Given this list of marker genes CRELD1, ST14, RPL35A, NOTCH3, HCCS, PMM2, POMGNT2, ANK1, SHROOM4, ROBO3, POLR1C, CRX, PDPN, PPP1R13L, ABCB6, RAF1, ATPAF2, ACTG1, MAPK1, CEP120, FH, IL12A, BBS12, MAPRE2, RRAS2, COX7B, COQ2, SRCAP, NHS, BBIP1, ERCC1, ABCA1, CRYBA4, DNA2, ZNF513, LAMB1, ATP7B, CHMP1A, RNU4ATAC (NCBI Gene Id 57788), MAK, CHD7, MAN2B1 (mannosidase alpha class 2B member 1), RPL18, TFAP2A, RNF113A, VSX1, RLIM, UROS, TUB, GNPAT, PDZD8, MIR204, LAMB3, IDH1, IQSEC2, SIN3A, MT-ND5, ATAD3A, RNF2, DSG4, ADAMTSL4, PLXND1, KRT74, TRIM37, DDB2 (NCBI Gene Id 1643), LUZP1, HERC2, APOA2, RPS10, CHSY1, PIGQ, SMAD4, RPE65, LRP5, MT-TV, ITPA, IMPG1, SMC5, PRG4, COL5A1, SF3B2, KMT2B, FREM1, FIG4, PRR12, COMT, B9D2, EIF2B2, GATA1, WDR35, SAMHD1, BLOC1S3, BBS7, B4GALNT1, KRT25, SLC4A4, DEAF1, PEX2, PEX19, MOCS1, SLC25A24, LPAR6, BTNL2, TMEM70, NIPBL, PPP2CA, DGCR2, FANCB, FLNB, IL10, SUFU, GATAD2B, ITPR1, DISP1, HLA-B, MTSS2, PCYT1A, ARCN1, FAS, NDN, BBS9, SLC40A1, SNRPN, HS2ST1, PPP1R17, CREBBP, PSAT1, PDE6G, FKRP, SLC39A8, B3GALNT2, FGD1, KCNV2 (potassium voltage-gated channel modifier subfamily V member 2), KRT83, NPHP4, ZBTB7A, POMT1, XRCC4, CEP41, RRAS, RPL15, PTPN11, SETBP1, COL2A1, ZFHX2, GALE, STIM1, NOG, GLA, OPN1LW, LAMC2, AASS, MAX, SLF2, SOX10 (SRY-box transcription factor 10), TRPV3, USB1, PRDM12, DBR1, DUX4, USH2A, SUOX, MYO7A, RPS17, PTCH1, NF2, MBTPS2, RP1, SLC2A1, FBN2, GALNT2, ATP5F1E, NDP, PACS2, PERCC1, ETFA, NAA60, SPEN, TBC1D2B, LYZ, SMC3, CRYGB, NF1, DDX6, SPRTN, MAPKAPK5, REEP6, CC2D2A, CLPB, ALDH18A1, IL2RB, RBP4, MINPP1, HSPA9, AGBL5 (AGBL carboxypeptidase 5), CBY1, ASH1L (NCBI Gene Id 55870), RFWD3, KIF11, ERCC5, TAP1, TBCE, STS, RP1L1, CBL, WAC, PDGFRB, IFNGR1, PIGG, PEX7, SULT2B1, TAF6, DDR2, ARSG (NCBI Gene Id 22901), TYRP1, CRYGD, RBP3, PANK4, TYR, PAH (phenylalanine hydroxylase), FDXR, SH3PXD2B, PEX13 (NCBI Gene Id 5194), VLDLR, POLA1 (DNA polymerase alpha 1, catalytic subunit), MAT2A, ARID1B, JAG1, IKZF1, HMX1, SOS2, PRKAR1B, PRPF8, AKT1, TCF4, TCOF1, MAP3K7, NR2E3, PHOX2B, ERCC4, KITLG, CCR1, PRPF4, TINF2, HLCS, FGF3, SLC33A1, TMEM67, FGF5, PDE6B, SEC24C, RNF13, USP45, MED13L, CAMK2B, GLRB, SHH, SETD5, GABRD, MT-ND1, H1-4, B9D1, TBC1D24, MT-TK, SETD2, NEUROD2, CLDN19, GAS1, GP1BB, ABCG8, BAP1, INVS, FLVCR1, TOGARAM1, NDUFB11 (NADH:ubiquinone oxidoreductase subunit B11), XPA, KDSR, PBX1, SMPX, CHD6, ROM1, GDF3, GJB4, DYM, TXNDC15, WRAP53, SLC2A10, TMTC3, DNAJC30, TENM3, SLC29A3, FKBP6, SLC39A4, KIAA0586, SDR9C7, BRCA2, DHCR7 (7-dehydrocholesterol reductase), LMNA, RPL9 (ribosomal protein L9), SLX4, HYCC1, CLDN11, ADAMTS17, TBR1, JAM3, CHST3, HDAC4, CCDC28B, MYT1L, ELN, FGFR3, ANTXR1, TONSL, RPS15A, PLCG2, CTDP1, ABCA4, CRYAA, RAB3GAP2, ADA2, CYSLTR2, DNMT3B, FOXH1, TUBGCP6, SDHC, TBC1D20, GTF2I, UBIAD1, VIM, CA8, ZFX, GNPTAB, TBX22, ASPH, NRL, RECQL4, EPHA2, MT-CO1, LRMDA, DYNC2H1, COL1A1, RAI1, CDHR1, TUBA3D, GTF2E2, SPRED2, MFAP5, NOTCH2, COL9A1, SDHB, COL4A4, GLI3, SHOC2, PTEN, MIPEP, NPHP1, COL8A2, RAP1B, USH1G (USH1 protein network component sans), RAD51C, HPS1, RB1, IL2RA, MYOC (myocilin), GLIS3, CRYBA2, FKTN, KIZ, RPS29, NOD2, GJA1, FRG1, ADNP, LAMB2, ERCC2, TGM1, TERT, ELP1, HK1 (hexokinase 1), HNRNPA2B1, HNRNPDL, COL9A3, TEAD1, RNF125, TMEM237, BBS4, IKBKG, LAMA3, H19, TBC1D7, CACNA1F, RPGR, PRPF3, MOCS2, VCP, EXOSC2, EDNRB, PRPH2, FLI1, CEP78, COL3A1 (collagen type III alpha 1 chain), PLCB4, KMT2C, LRP2, RRM2B, OCLN, MT-CO3, MKKS, MPV17, PLEC (NCBI Gene Id 5339), SEC23B, ZEB1, ALG2, TREX1, PDE6D, DHX38, ELMO2 (NCBI Gene Id 63916), MMP14, KDM5A, CNBP, NPHP3 (nephrocystin 3), ATP6V1B2, POMK, BCAP31, FOXL2, ARSL, TGFB3, DTNBP1, UBE3A, AP3D1, CLIP2, MT-CO2, DLST, LRAT, VHL, GNAS, EMC1, GTF2IRD2 (GTF2I repeat domain containing 2), PRTN3, NPM1 (nucleophosmin 1), ESPN, USH1C, TCTN1, KMT2D, SEM1, POLR1D, FAM111A, AFF4, MRPS28, TRIM28, BDNF, CYP1B1, KIF21A, TWIST2, ERCC6 (ERCC excision repair 6, chromatin remodeling factor), DLX5, VPS35L, REV3L, GALK1, MMP2, MT-TQ, PNPT1, ERCC3, CEP290, IFT27, CEP164, MBD5, YAP1, WFS1, PRDM16, UBE3B, PEX11B, MT-TC, FBXW7, EBF3, POLG, CAMSAP1, ACADS, RASA2, MERTK, HDAC8 (histone deacetylase 8), RIT1, AIRE, ACTA2, RAB23, PLOD3, NGLY1, RPS26, USF3, SCLT1, TP63, POLH, GALT, GBA1, B3GAT3, FERMT1, PIKFYVE, TCEAL1, CLN3, CFAP410, SEC23A, SLC24A5 (NCBI Gene Id 338402), WIPF1 (NCBI Gene Id 7456), TBL2, CRPPA, FTL, WNT3, EPG5 (NCBI Gene Id 654033), CERKL, ERI1, UNC45B, EPHX2, LIG4 (DNA ligase 4), CRB1, KDM6A, FANCF, SMG8, TBX1, CRYAB, RAB27A, PEX26, FGFRL1, DSE, SRY, BRIP1, CCDC22, GJA8, COL25A1, DLL4, ARHGEF2, CRYBA1, DPYSL5 (dihydropyrimidinase like 5), CD247, NMNAT1, MVK, NEUROG1, ZNF469 (NCBI Gene Id 84627), STXBP1, HLA-DPB1, C1QBP, TMEM107, TMEM216, NAXD, HLA-DRB1, SLC4A11, LBR, P4HTM, TMEM138, XPC, MAD2L2, PIGW, MEGF8 (multiple EGF like domains 8), ARHGAP31, C1QTNF5, TYMS, EP300, FGFR2, SLC20A2, LEMD2, PHOX2A, UBE2A, KIFBP, MORC2, MYO1H, NUP188 (nucleoporin 188), AMMECR1, PIGY, SLC35C1, IL23R, ARMC9, TAT, IFT172, MYO5A, MED12L, DGCR6, ANAPC1, SMC1A (NCBI Gene Id 8243), PTCH2, RPGRIP1L, KANSL1, ERCC8, SDHD, CDH2, RDH11, FANCE, EDEM3, PRCD, CHRDL1, SPRED1, FBLN5, PITX2, BCS1L, TWNK, KCNA4, TGIF1, CYP7B1, COL5A2, GALNS, NACC1, GRHL2, NHP2, MSH6, FLG, RPS24 (ribosomal protein S24), BBS10, COL17A1, EDN3, PRKCZ, NEK2, INPP5K, COL7A1, KRT3, COL1A2, SMAD2, RPL35, PIGO, PHF6, ALX1, ARPC4, ALX3, PDE6A, PCSK9, SUMF1 (sulfatase modifying factor 1), CEP57, ADAR, KAT6A, IQCB1, ATP2A2, CNGA1, TRIM32, OPN1MW, PRIM1, AGBL1 (NCBI Gene Id 728206), FOXC1, UBE2T, KLHL7, HRAS, LOX, RPL27, ANO10, MAG, MBTPS1, PIK3CA, MAFB, GHR (growth hormone receptor), SMO, SNRNP200, KIDINS220 (kinase D interacting substrate 220), FBN1, EOGT, SPTLC1, HARS1, ZNF335, LOXL1, CDON, TRPM3, PEX6, PAX3, GSR, PPP1R12A, CHUK, IL6ST, RP9, SOS1, BCOR, FANCM, GFAP, KRT5, RNU4-2, BFSP1, OVOL2, KLLN, KIAA1549, LIG3, ATP8A2, MPZ, IMPDH1, ETFB, PIEZO2, RAB18, CSPP1 (NCBI Gene Id 79848), IDS, FUCA1, ARL2BP, MAB21L2, ABCA2 (ATP binding cassette subfamily A member 2), EFEMP1, PEX12, LSM11, TGFBR2, HGSNAT, POLR3GL, IFT140, GJB2, RNH1, ERAP1, FIBP, LCAT (NCBI Gene Id 3931), RRAGC, HYLS1, LZTFL1, EDC3, WASHC5, DUX4L1, ADGRV1, PUF60, RPS19, UBA5, MAP2K2, RTN4IP1, LIPH, HNRNPA1, GUCA1B (NCBI Gene Id 2979), EXOSC5, ARL3, WDR37, WNT10B, BLOC1S5, PYCR1, GJA3, ARL6, OTUD5, CPT2, MT-TS2, NLRP1, FANCD2, SMARCB1, KRT81 (NCBI Gene Id 3887), IFT80, FGFR1, UFD1, ATP5MK, PEX5, EIF4H, ARL6IP6, BBS2, NEU1, RLBP1, TMEM127, ITM2B, TCTN2, VARS1, LAS1L, XRCC2, PTH1R, PIGT, YY1, CHM, SEC31A (SEC31 homolog A, COPII coat complex component, NCBI Gene Id 51424), ROR1, PRKAR1A, RIPK4, PIK3R1, TACSTD2, DPAGT1, NOP10, DCN, XPR1, ADAMTSL1 (ADAMTS like 1), HSF4, PTPN2, CRLF1, KLRC4, MPLKIP, RAD21, MPDZ, ABHD12, HEATR3, UBE4B, ABHD5, PCDH15, IFIH1, DPYD, PAX6, WDR73, PMP22, PNPLA6, BAZ1B, MLPH, ALOXE3, IDUA, ANO1, CHST6, ARL13B, AIPL1, IARS2, CNGB3, PCARE, RPL11, CRIPTO, KCNH1, STX1A, PRMT7, BMP4 (bone morphogenetic protein 4), VWA8, BUD23, FOXC2, DNAI1, MED11, PRUNE1, BEST1, PLK4, TBL1XR1, PORCN, COQ6, HPS6, EBP, TRIM44, BLTP1, KRT86, RNU7-1, CNGA3, SMCHD1, SLC25A11, MKS1, IDH3A, CRYBB2, COLEC10, CFAP418 (NCBI Gene Id 157657), CANT1, UBAP2L, MSMO1, NFIX, GNAQ, IDH3B, POGZ, FANCG (NCBI Gene Id 82603), LDHD, APOA1, TERC, BRCA1, PITX3, PSMB8, ELP4, FGF10, APOB, GJB3, TBX15, OPA1, FBXL4, HPS4, ARL2, ANKRD11, MT-ATP8, PAX2, PRPF6, MT-TF, GRIA1, NRCAM, TKT, IGF1R, MAFA, ARSB, MYMK (myomaker, myoblast fusion factor), KRT12, WDPCP, B3GALT6, PLOD1, FGF8, WDR45, CTC1, SRD5A3, CRYBB3, SDHAF2, UROD (NCBI Gene Id 7389), TMEM231, NEK9, PIGL, SMARCAL1, GMPPB, RPL26, POLR1A (RNA polymerase I subunit A), SALL4, RPS7, TGM3 (NCBI Gene Id 7053), NAGA, NAA10, COL4A6, ACTB, TSR2, RAX, PHYH, PPP2R5D, NIPAL4, ESCO2, IGBP1 (immunoglobulin binding protein 1), TMEM270, CRYBB1, PARN, DYNC2I2, PROM1, PXDN, MECP2, DYNC2I1, TRIP13, MTTP, CHD3, RDH12, TUBB3, KCNAB2, ALDH6A1, COL11A2, RPS6KA3, APOE, LIPC, ARVCF, PLCB3, RHO, NSD2, COL9A2, AP1S1, PEX3, ALG8, LZTR1, LIM2, CAV1, WDR19, FANCA, BBS5, REST, OCA2, TUBB2B, FOSL2, KRT14, ATP11A, KDM5B, NRAS, AHDC1, KIF1B, MED25, HLA-A, DNMT1 (DNA methyltransferase 1), SC5D, CTBP1 (C-terminal binding protein 1), MT-TL1, TGFBI, FLII (NCBI Gene Id 2314), PRDX3 (peroxiredoxin 3), GEMIN4, SIX6, COG4, OAT, CHMP4B, KIAA0753, NCF1 (neutrophil cytosolic factor 1), BLOC1S6, EYS, RP2, COPB1, PEX10 (peroxisomal biogenesis factor 10), LRP4, SERPING1, SLC38A8, GMPPA, MDH2, AHI1, WT1, SPATA7, PEX14, LYST (NCBI Gene Id 1130), SPTBN1, C12orf57, SLC25A4, KATNIP, POMGNT1, MT-TW, CCDC47, VSX2, INTS1, INPP5E, SBF2, LONP1, ETFDH, ZNF423, PIK3C2A, CNGB1, SEMA3E, BUB3, FUT8, FAM111B, CAPRIN1, CTNS, TULP1, LARGE1, TTC8, CHN1, ZEB2, COLEC11, SALL1, MC1R, SIL1, PTH, LIFR, EPS15L1, OCRL, METTL27, CEP104, CIB2, AARS1, SLC7A14, EED, APC2, TAOK1, MRAS, SEMA4A, SPINT2, EPCAM, KCNJ13, BUB1, RNASEH2B, SDCCAG8, GTF2IRD1, POU6F2, CYP27A1, SH3TC2, ATP5F1D, PIGV, ASAH1, PNPLA1, MMP1, DGCR8, BUB1B, NODAL, TUBA1A, TRAPPC2, RPL31, GSN, PRKAG2, DOCK6, LDLR, CDH23, ARHGEF18, NR2F1, OFD1, LOXL3, RDH5, TRAPPC11, TGFBR1 (NCBI Gene Id 7046), ZMPSTE24, RIC1, ATP10A, PRKG1, PAK2, LMBRD2, ZMIZ1, RSPO2, ALOX12B, HGD, MARK3, TSPAN12, DHDDS, AP1B1, SLC25A13, DMPK, NCAPG2, GDF6, CRYGS, POLG2, GBA2, HTRA2, PTPN22, GUCY2D, BTRC, GNA11, CENPF, SAG, FBXW4, RPS27, FAM161A, MYH9, RAB3GAP1, TUBB4B, APC, CTNNB1, BRD4, RREB1, TBCK, VPS13B, TBX4, ESAM, AGA, MIR184, PEX16, RHOA, WDR81, SNAI2, TRAF3IP1, PEX1, GLI2, MT-CYB, RET, RPL8, CLDN16, IL12A-AS1, SCUBE3, CPLANE1, DLX6, FOXE3, FAM50A, ENTPD1, AAAS, JMJD1C, SLC16A12, AMACR, WHRN, ALDOB, COL4A1, RPS20, FANCC, PIBF1, DAG1, KRT71, GNPTG, MCOLN1, CARS1, DNMBP, AGK, NSUN2, MYH11, HMGB3, KCNN3, PDZD7, JAM2, GFER (growth factor, augmenter of liver regeneration), ALDH3A2, DNAJC21, BBS1, DIS3L2, CYP4V2, RNASEH2A, ESS2, FAR1, OPA3, RALGAPA1, PGAP2, COL4A3, BCKDK, RNASEH2C, ERF, TRPV4, FYCO1, TUBG1 (tubulin gamma 1), MMP23B, MAGEL2, CLTCL1, ALMS1, B3GLCT, GALM, STAT4, LIMK1 (NCBI Gene Id 3984), CTCF, ZNF526, PRDM5, TBX2, TEK, GUSB, WRN, BRCC3, GJB6, GZF1, NR4A2, GTPBP2, CTLA4, SIX3, NSD1, DLL1, ZBTB20, VPS37D, AP3B1, DGUOK, SCARF2 (scavenger receptor class F member 2), CEP19, KCTD1, HLA-DPA1, TOPORS, MYORG, KCNMA1, GLB1, RAD51, MITF, DST, GTF2H5, ALG3, TDRD7, THSD4, CAMTA1, CASZ1, PDGFB, ROBO1, LCA5, HIRA, GORAB, SOX2 (SRY-box transcription factor 2), ANKRD55, RFC2, KIT, OTX2, RPL5, SNUPN, MAPK8IP3, DKC1, MFRP, NLRP3, ATP6V1A, PRPF31, FLNA, TWIST1, INTS11, CDH11, BRF1, RPS28, MIP (NCBI Gene Id 4284), RBPJ, ABCD1, HMBS, DCT, HHAT, PALB2, ADAMTS18, XYLT2, USP9X, VCAN, BFSP2, COL11A1, RTEL1, LMX1B, AEBP1 (AE binding protein 1), RXYLT1, ATP5F1A, MASP1, POMT2, RGR, KRAS, VPS4A, RERE, VAC14, WAS, MLXIPL, MYLK, CLRN1, ABCA12, SF3B1, PRSS56, CHD4, PHGDH, FKBP14, UBAC2, CPLX1, GPC3, AMER1, MEFV, HSPG2, NELFA, PGAP3, LETM1, MYSM1, NTRK1, FANCI, TLR4, CA4, GPR143, CBS, RECQL, MED27 (mediator complex subunit 27), TCTN3, FZD5, TGFB2, PDE4D, RD3, RPGRIP1, TMEM218, TARS1, ZIC2, SIPA1L3, EHMT1, LTBP2, ZNF408, CHST14, MAF, AHR, CRYGC, SCN9A, FBXW11, FRAS1 (NCBI Gene Id 84949), POLR3A, P3H2, IFT74, PQBP1, CERS3, SLC45A2, TFE3, FANCL, POLR1B, MTAP, DNM1L, MAB21L1 (mab-21 like 1), KERA, GCNT2, SKI, TELO2, SREBF1, NOTCH1, COL4A5, B4GAT1, MT-ND6, FSCN2, SCAPER, TUBB, CPAMD8, DACT1 (NCBI Gene Id 51339), DYRK1A (NCBI Gene Id 1859), LSS, CTSA, ADAMTS10, STX16, ATOH7, PSMC3, HPS5, C4A, IMPG2, HEY2 (hes related family bHLH transcription factor with YRPW motif 2), IFT88, TKFC, TNPO2, SDHA, MT-ATP6, RBM8A (NCBI Gene Id 9939), GJA5, SALL2, GNB5 (G protein subunit beta 5), PIGN, SMAD3, COL18A1, FZD4, here is a description of the gene set: studied in species Homo sapiens Human Gene Set: HP_ABNORMAL_ANTERIOR_EYE_SEGMENT_MORPHOLOGY Abnormal anterior eye segment morphology An abnormality of the anterior segment of the eyeball (which comprises the structures in front of the vitreous humor: the cornea, iris, ciliary body, and lens).